The following is a description of a gene set: Mouse Gene Set: GOBP_NEGATIVE_REGULATION_OF_SUPRAMOLECULAR_FIBER_ORGANIZATION studied in species Mus musculus Any process that stops, prevents or reduces the frequency, rate or extent of fibril organization., and this is the list of marker genes: Arhgef7, Frmd7, Dlc1, Pfdn1, Tbcd, Cib1, Spef1, Gas2l2, Cryab, Pfdn5 (NCBI Gene Id 80400), Swap70, Pfdn6, Arhgap6, Eml4, Was, Sptan1, Add2, Tmsb15b2, Tlr2, Kank1, Gsn, Ssh1, Hspa8, Gmfb, Fgf13, Met, Nav3, Mid1ip1, Bmerb1, Mapre1, Clu, Atxn7, Clip3, Hdac6, Add3, Sptb, Tmod2, Ttbk2, Rhpn1, Pik3r1, Myadm, Carmil2, Tmsb4x (thymosin, beta 4, X chromosome), Tjp1, Tacstd2, Camsap1, Dmtn, Tpx2, Capza1, Twf2, Arap1, Coro2b, Arhgef2, Pick1, Tmod4, Dnai3, Apc, Arhgap28, Arfgef1, Camsap2, Cracd, Wdr47, Capza3, Arpc2, Hdgfl3, Emilin1, Ckap2, Dbnl, Kank4, Camsap3 (NCBI Gene Id 69697), Capza2, Gmfg, Capg, Cav3, Coro1b, Phldb2, Clasp2, Map1b, Trem2, Bbof1, Sgk1, Prkn, Myh9, Myoc, Snca, Capza1b, Ssh2, Bbs4, Rhpn2 (rhophilin, Rho GTPase binding protein 2), Inpp5k, Eml2 (NCBI Gene Id 72205), F11r, Avil, Ppp1r9a, Dbn1, Mtpn, Eps8, Map2 (microtubule-associated protein 2), Specc1l, Twf1, Tmod1, Tpm1, Katnb1, Tmsb15l, Kank2, Coro1a, Ppfia1, Flii, Plekhh2, Lmod1, Pik3ca, Inpp5j, Wasf2, Taok1, Stmn2, Pfn2, Togaram2, Arpin (NCBI Gene Id 70420), Pfdn4, Shroom2, Kank3, Lmod3, Map6d1, Pfdn2, Rp1 (NCBI Gene Id 19888), Vill, Stmn1, Gas2l1, Chadl, Apc2, Mkks, Lima1, Ctnna2, Cyrib, Trim54, Smad4, Dyrk1a, Ssh3, Sptbn1, Capzb, Capn1, Diaph3, Spta1, Prkcd, Ldlr, Arhgef18, Tubb4a, Tmod3, Shank1, Rdx, Fkbp4, Fhod3, Clasp1 (NCBI Gene Id 76707), Svil, Vil1, Scin, Evl, Lmod2, Apoe, S1pr1, Pfn1, Shank3, Hip1r, Slit2, Ccdc88c, Carmil1, Vbp1, Pak2, Mid1, Cfl1, Cdh5, Hspg2, Pecam1, Cgnl1, Map3k1, Mfn2, Tmeff2, Add1, Map1a